The following is a description of a gene set: from publication Lee JH, Ulrich B, Cho J, Park J, Kim CH (PMID 21768398) Human Gene Set: GSE22025_UNTREATED_VS_TGFB1_TREATED_CD4_TCELL_UP species: Homo sapiens We examined the global gene expression pattern of T cells regulated by progesterone to gain further insights into the regulatory mechanisms of progesterone. We found 325-347 cord blood T cell genes up or down-regulated by P4 in the presence or absence of exogenous TGFb1. Peripheral blood T cells were relatively unresponsive with only 30-genes regulated by P4. IL-6 receptor (IL-6R) expression was greatly down-regulated by progesterone in cord blood, but not PB, T cells. Overall, these differences in gene expression are consistent with the differential responses of cord blood and peripheral blood T cells to progesterone. To gain insights into the differences of progesterone and control dendritic cells, we performed a microarray study and found ~genes regulated by progesterone in dendritic cells. The gene expression information suggests that progesterone has the potential to alter dendritic cell responses to cytokines, chemokine production, and migration which in combination would control T cell differentiation. Genes up-regulated in CD4 T cells: untreated versus TGFB1., and this is the list of marker genes: MPP1, STK38L, YWHAH, FER, CCNB2, FADS2, GNAI1, JUN, EXT1, CELSR3 (NCBI Gene Id 1951), SLC16A4, EIF2S1, TP53I11 (NCBI Gene Id 9537), OXCT1, ATP2B4, FMOD, UPK1A, WDHD1, CHERP, ATP6V0A2, DIXDC1, NPAS2, MAP3K8, TP53BP2, GTPBP10, ENPP1, FZD7, SERPINE1, TMPRSS11D, IL1RAP, NFATC3, DYNLT1 (dynein light chain Tctex-type 1), PPP6R1, DYRK2, ITGAM, CSTB, CBFB, MET, SCGB1D2, GRPEL1, SREBF2, TMPRSS6, NID2, FNDC3A, TUBA4A, DLC1, DDX39A, RRP12, BMPR2, APOE, MAN2A2, TIMP2, SOX10, COL4A3, TFAM, ANK1, NFKBIE, XCL2 (NCBI Gene Id 82261), PLCL2 (NCBI Gene Id 23228), GRB10, CRAT, ANXA11, EPAS1, RARS1, LAPTM4B, CD47, ANXA1, KCTD17, ACSL1, ATF5, PHLPP2 (NCBI Gene Id 23035), KCNA6, CYP2C8, COL9A2, UQCRQ, RAB5A, MATK, NDUFA2, SLC6A3, IGSF3, DPP6, STARD13, SNRPG, CTSL, FURIN, SFT2D2, C1orf216, GJA5, TNFSF11, DSCR4, GADD45G, HCN4, PDHA2, SLA, ATF3, PKIA, GRM5, PBX3, NBAS, GPX4, IER2, UFD1, GNGT1, ARHGEF15, ABCC2, RNF113A, SOCS1, SLC39A8, LY86, F5, POMC, S100P, SLC17A3, BASP1, VWF, SELL, GNA15, AMPD2, ETFB, CACNA1D, ZPR1, GPR183, SLC7A8, RNASE2, MLH1, PPP1R16B, RPL23AP53, TUBB4B, MTNR1B, SMAD2, KCNJ2, DYRK3, SPINK5, LTA4H, INSIG1, ECPAS, ULK1, RGS16, RBM14, PIN1, GPD1L, HBEGF, GPRC5A, ATG4A, NINL, TEX30, ENO2, IL10RA, SLC3A2, AGT (angiotensinogen), ST6GAL1, SCN8A, TOP2A, PCDHA9, CENPE, ADCY8, GABRA1, CBY1, CLDN5, SLC22A14, DIAPH2, OR2H2, SLC7A5, PPP1R10 (NCBI Gene Id 5514), RSAD2, FUT8, GRK4, MISP, ARSD, LCOR, ADAM19, FARP1 (NCBI Gene Id 10160), RRAGD, ABCD3, DDO, GFI1, PGM3, SPINT2, TIAM1, SH2D2A, GATB, SLC4A2, CDK17, ATP6V1H, SEL1L3, GOT2, PPP1R12A, RPP14, SUSD6, ASB1, CCT6B, KIAA0087, COL4A1, MYBPC1, TAC1 (NCBI Gene Id 6864), AMIGO2, MTERF1, HGFAC, PITRM1